The following is a description of a gene set: studied in species Mus musculus Genes predicted to be targets of miRBase v22 microRNA mmu_miR_7666_3p in miRDB v6.0 with MirTarget v4 prediction scores > 80 (high confidence targets). from publication Chen Y, Wang X (PMID 31504780) Mouse Gene Set: MIR_7666_3P, and this is the list of marker genes: Cacna2d1, Klhl1, Capns2, Cdk14, Bcl11a, Ngef, Prrt2, Tc2n, Srsf11, Bclaf1, Epc2, Prkcb, Klhl31, Tshz3, Snx2, Thoc2, Ccnyl1, Lsm14a, Kcna2, Cnksr2, Septin6, En2, Phf19, Krt10, Cav1, Kpna1, Zbtb10, Ppp6r2, Acvr1, Fam184a, Taf13, Hars1, Sox6, Clcn3, Faf2, Il23a, Hdgfl3, Nfyc, Ube2b, Nedd9, Tnpo1, Stmn2, Hoxc10, Klf4, Hic2, Tbkbp1, Herc2, Cdk17, Aste1, Fstl5, Atp2b1, 4930571K23Rik, Pycard, Cacna1c, Ppp6c, Zfx, Hs6st1, Cops2, Naa30, Gnpnat1, Tmem25, Armc1, Zswim6, Eva1a, Rdh10, Xpo1, Cnot9, Tln2, Megf11, Fam13a, Etf1 (NCBI Gene Id 52117), Tmem248, Gpd2, Kirrel1, Ccnj, Fam169a, Hipk3, Stambp, Sptan1, Tmem196, Swsap1, Zfp280d, Gabrg2, Zmynd11, Mfsd14b, Mecp2, Jakmip2 (janus kinase and microtubule interacting protein 2), Kcnab1, Ly6c1, Tjp1, Psmf1, Idi1, Entrep3, Spats2l, Pik3cb